The following is a description of a gene set: Mutations in the APC tumor suppressor gene are common in colorectal and other cancers and cluster in the central mutation cluster region (MCR) of the gene. These mutations generally result in truncated proteins that destabilize the destruction complex and result in elevated WNT pathway activation. part of: Signaling by APC mutants Reactome Pathway: APC truncation mutants have impaired AXIN binding species: Homo sapiens, and this is the list of marker genes: PPP2R5B, CSNK1A1, APC, PPP2CA, PPP2R1B, PPP2CB, GSK3B, PPP2R1A, PPP2R5D, AXIN1, PPP2R5E, AMER1, PPP2R5C, PPP2R5A